Given this list of marker genes AMDHD2, GFPT2, UAP1, NAGK, PGM3, RENBP, GFPT1, GNPNAT1, here is a description of the gene set: Human Gene Set: REACTOME_SYNTHESIS_OF_UDP_N_ACETYL_GLUCOSAMINE Synthesis of UDP-N-acetyl-glucosamine species: Homo sapiens